Given this list of marker genes GLCE, NDST3, SLC10A7, CSGALNACT1, NDST2, NDST4, EXT2, XYLT2, ANGPT1, EXT1, NDST1, here is a description of the gene set: The chemical reactions and pathways resulting in the formation of heparin proteoglycans, which consist of a core protein linked to a heparin glycosaminoglycan. The heparin chain is composed of the repeating disaccharide unit beta-(1,4)-N-acetyl-D-glucosamine-alpha-(1,4)-hexuronic acid, the former being either sulfated or deacetylated on its amino group as well as sulfated on one of its hydroxyl groups, and the latter being a mixture of sulfated and nonsulfated D-glucuronic and L-iduronic acids. Heparin is similar to heparan sulfate but it contains more N-sulfate and O-sulfate groups. Heparin chains are covalently linked to serine/threonine residues (O-linked) of the core protein via a tetrasaccharide linker sequence (xylose-galactose-galactose-glucuronate). species: Homo sapiens Human Gene Set: GOBP_HEPARIN_PROTEOGLYCAN_BIOSYNTHETIC_PROCESS